Given this list of marker genes Bmp2, Slc22a6, Wnt9b, Gli3, Lzts2, Wwtr1, Pax2, Heyl, Fgf1, Mir217, Hoxa11, Lhx1, Pou3f3, Hs3st3b1, Calb1, Six1, Ilk, Basp1, Cd44, Cd2ap, Ednra, Pspn, Pbx1, Ednrb, Wnt1, Edn1, Stat1 (signal transducer and activator of transcription 1), Pgf, Foxd1, Bcl2, Grem1, Fmn1, Sall1, Fgf8, Ctnnbip1, Wnt2b, Osr1, Ext1, Abcc2, Npnt, Pax8, Irx1, Tgfb1, Nog, Wnt4, Myc (NCBI Gene Id 17869), Tcf21 (NCBI Gene Id 21412), Magi2, Dchs1, Yap1, Hes5, Wnk4, Vegfa, Adamts16, Asxl1, Podxl, Foxc2, Kif26b, Commd5, Maged1, Agt (NCBI Gene Id 11606), Cited2, Agtr1a, Gzf1, Mir216a, Irx2, Notch2, Acat1 (acetyl-Coenzyme A acetyltransferase 1), Six4, Hoxb7, Ctns, Iqgap1, Lamb2, Fat4, Smad4, Dll1, Wt1, Mir216b, Fgf2 (NCBI Gene Id 14173), Klf15, Myo1e, Cd34, Klhl3, Mef2c, Ampd2, Irx3, Pkd1, Aqp1, Cited1 (Cbp/p300-interacting transactivator with Glu/Asp-rich carboxy-terminal domain 1), Pdgfb, Hes1, Hs2st1, Tacstd2, Hs3st3a1, Prom1, Dspp, Eya1, Gdnf, Smo, Wnt6, Timeless, Umod, Sox9, Pkd2, Nphs1, Mtss1, Dlg1, Sox8, Lama5, Notch1, Hnf1b, Hey1, Jag1, Bmp4 (bone morphogenetic protein 4), Adipoq, Wnt7b, Greb1l, Agtr2, Gata3, Ptch1, Lif, Aqp11 (NCBI Gene Id 66333), Tfap2b, Gpc3, Wnt11, Foxj1, Nphs2, Shh, Foxc1, Tmem59l, Six2, Lgr4, Ctnnb1, Hoxd11, Agtr1b, Slc22a1, Ptpro, Cd24a (CD24a antigen), here is a description of the gene set: studied in species Mus musculus Mouse Gene Set: GOBP_NEPHRON_EPITHELIUM_DEVELOPMENT The process whose specific outcome is the progression of the nephron epithelium over time, from its formation to the mature structure. An epithelium is a tissue that covers the internal or external surfaces of an anatomical structure. The nephron epithelium is a tissue that covers the surface of a nephron.